Given this list of marker genes Ezr (NCBI Gene Id 97496), Ptpn22, Gadd45a, Map3k20, Dsc2, Map3k6, Ager, Met, Map2k6, Map2k3, Rell1, Hand2, Kcnj8, Sash1, Zfp36, Cyld, Spi1, Mapk11, Mapkapk2, Map3k4, Ulk4, Map3k3, Trpv4, Zfp36l1, Map3k7, Lep, Map1lc3a, Bmp4, Atf2, Stk39, Fgfr3, Gadd45g, Gadd45b, Becn1, Bmp2, Phlpp1, Vegfa (NCBI Gene Id 22339), Ccr2, Gsn, Kcnn4, Gdf6, Sphk1, Xdh, Dusp1, Dlg1, Map3k15, Trem2, Il1b, Map3k5, Dsg3, Dab2ip, Per1, Atf7, Zc3h12a, Dusp10, Mink1, Pja2, Cav3, Mapk14, Nr2c2, Rell2, Oprk1, Hgf, Mfhas1, here is a description of the gene set: A MAPK cascade containing at least the p38MAPK (MAPK14) MAP kinase, or Hog1 in yeast. It starts with the activation of a MAP3K, and the consecutive activation of a MPK2K and of p38MAPK. The cascade can also contain an additional tier: the upstream MAP4K. The kinases in each tier phosphorylate and activate the kinases in the downstream tier. The p38MAPK cascade is activated by stress signals, including hyperosmolarity, as well as by G protein-coupled receptors, growth factors, and cytokines, and results in cellular responses such as cell proliferation, cell differentiation, apoptosis and inflammation. species: Mus musculus Mouse Gene Set: GOBP_P38MAPK_CASCADE